The following is a description of a gene set: species: Homo sapiens Human Gene Set: MIR5697 from publication Chen Y, Wang X (PMID 31504780) Genes predicted to be targets of miRBase v22 microRNA hsa-miR-5697 in miRDB v6.0 with MirTarget v4 prediction scores > 80 (high confidence targets)., and this is the list of marker genes: BARD1, RTN1, NID1, MLLT10, PSAP, NCEH1, SH3D19, ULK2 (unc-51 like autophagy activating kinase 2), TET3, ECHDC2, TXNDC16, ANKS1B, SEC63, B3GNT5, ERLIN1, DTD2, NUDT11, CD200, THAP8, SLC38A7 (NCBI Gene Id 92914), FRMD4B, MAEA, RAPGEF2, PLEKHH1, ANKRD34C, COPG2, SLC2A13, PPP3R1, ZDHHC6, OXNAD1, LRRTM3, CFAP45, TXLNG, RHOQ, TMEM200B, BOD1, C2CD2L, USH2A, KRIT1, OSBPL2, ARHGAP17, EPHA5, OSBPL11, SLC12A2, SLC45A4 (NCBI Gene Id 57210), CIBAR1, TNPO1, FOXJ3, RCN2, TBC1D4, NAB1, MGAT4A, MAB21L1, COL19A1 (NCBI Gene Id 7950), HS3ST3A1, STRBP (spermatid perinuclear RNA binding protein), XKRX, SPTLC2, ALDH5A1, KIR2DL3, CREBRF, OVOL2, UBR1, BOD1L2, DNAJA1 (DnaJ heat shock protein family (Hsp40) member A1), TRPC3, BLOC1S2, REEP4, HS3ST1, FAM98A, ZSWIM6, UBE4B, ZNF608, SLC19A2, PLOD2, AMOT, RPS6KA6, USP37 (NCBI Gene Id 57695), EIF4G2, CREBZF, SLC25A16, SACS, PURA, COX5A, GSK3B, COL1A2, CHORDC1, PALM3, RCN1, RBM24, KIR2DL1, USP27X, SRSF11, RASSF3, G3BP2, SMAD1, TET2, PPP4R3A, CHAC1, STRADB, ARAP2, ARPP19, LSM11, RCBTB1, CARMIL1, MAP7, CDK8, LIMS1, FA2H, RBMS1, NOL4, EP400, SLC7A11, KPNA2, DLG1, USP3 (NCBI Gene Id 9960), SLC30A7, AMD1, ZNF598, MTM1, FCAR, ZNF662, USP9X, VPS13C, ZDHHC22, KIR2DL4, SPESP1, SLK, FBXO11, MFHAS1, SLC4A7, SRCAP (Snf2 related CREBBP activator protein), CDH20, ATP1A2, MAP3K13, ADAM17, CHFR, ANKS1A, NAP1L5, PMAIP1, SKP2, KCNH7, KIR3DL3, KIR3DL1, ARHGAP12, TNRC6B, RIPPLY3, MCL1, DLG5, ADM, FBXO42, KLHL42 (kelch like family member 42), DMXL1